The following is a description of a gene set: studied in species Homo sapiens Assembly of active LPL and LIPC lipase complexes Human Gene Set: REACTOME_ASSEMBLY_OF_ACTIVE_LPL_AND_LIPC_LIPASE_COMPLEXES, and this is the list of marker genes: LMF2, CREB3L3, LPL (NCBI Gene Id 4023), GPIHBP1, LMF1, ANGPTL8, FGF21, PCSK5, ANGPTL3, APOC2, MBTPS2, FURIN, ANGPTL4, PCSK6, APOA5, MBTPS1, APOA4, LIPC, CIDEC